The following is a description of a gene set: Human Gene Set: REACTOME_SHC1_EVENTS_IN_ERBB2_SIGNALING studied in species Homo sapiens SHC1 events in ERBB2 signaling, and this is the list of marker genes: GRB2, NRG1, ERBB4, SOS1, ERBB2, PRKCA, EGF, BTC, NRG3, ERBB3, EGFR, SHC1, EREG, HRAS, PRKCE, HBEGF (NCBI Gene Id 1839), NRAS, NRG2 (neuregulin 2), NRG4, PRKCD, KRAS, PTPN12